The following is a description of a gene set: Mouse Gene Set: GOBP_GDP_L_FUCOSE_METABOLIC_PROCESS studied in species Mus musculus The chemical reactions and pathways involving GDP-L-fucose, a substance composed of L-fucose in glycosidic linkage with guanosine diphosphate., and this is the list of marker genes: Fuom, Slc35c1, Fut8 (NCBI Gene Id 53618), Fcsk, Gmds, Slc2a1, Fpgt, Gfus